The following is a description of a gene set: SARS-CoV-1 encodes eight subgenomic RNAs, mRNA2 to mRNA9. mRNA1 corresponds to the genomic RNA. The 5' and 3' ends of subgenomic RNAs are identical, in accordance with the template switch model of coronavirus RNA transcription. Genomic positive strand RNA is first transcribed into negative sense (minus strand) subgenomic mRNAs by template switching. Negative sense mRNAs subsequently serve as templates for the synthesis of positive strand subgenomic mRNAs. As shown in murine hepatitis virus (MHV), which is closely related to SARS-CoV-1, negative-sense viral RNAs are present in much smaller amounts than positive-sense RNAs. Of the eight subgenomic mRNAs of SARS-CoV-1, mRNA2 encodes the S protein, mRNA3 is bicistronic and encodes proteins 3a and 3b, mRNA4 encodes the E protein, mRNA5 encodes the M protein, mRNA6 encodes protein 6, and bicistronic mRNA7, mRNA8 and mRNA9 encode proteins 7a and 7b (mRNA7), 8a and 8b (mRNA8), and 9a and N (mRNA9), respectively. The template switch model of coronavirus involves discontinuous transcription of subgenomic RNA, with the leader body joining occurring during the synthesis of minus strand RNAs. Each subgenomic RNA contains a leader transcription regulatory sequence (leader TRS) that is identical to the leader of the genome, appended via polymerase “jumping” during negative strand synthesis to the body transcription regulatory sequence (body TRS), a short, AU-rich motif of about 10 nucleotides found upstream of each ORF that is destined to become 5' proximal in one of the subgenomic mRNAs. The 3' and 5'UTRs may interact through RNA–RNA and/or RNA–protein plus protein–protein interactions to promote circularization of the coronavirus genome, placing the elongating minus strand in a favorable topology for leader-body joining. The host protein PABP was found to bind to the coronavirus 3' poly(A) tail and to interact with the host protein eIF-4G, a component of the three-subunit complex that binds to mRNA cap structures, which may promote the circularization of the coronavirus genome. Two viral proteins that bind to the coronavirus 5'UTR, the N protein and nsp1, may play a role in template switching. The poly(A) tail is necessary for the initiation of minus-strand RNA synthesis at the 3' end of genomic RNA. Elongation of nascent minus strand RNA continues until the first functional body TRS motif is encountered. A fixed proportion of replication-transcription complexes (RTCs) will either disregard the TRS motif and continue to elongate the nascent strand or stop synthesis of the nascent minus strand and relocate to the leader TRS, extending the minus strand by copying the 5' end of the genome. The completed minus-strand RNAs then serve as templates for positive strand mRNA synthesis. Reactome Pathway: Transcription of SARS-CoV-1 sgRNAs part of: SARS-CoV-1 Genome Replication and Transcription species: Homo sapiens, and this is the list of marker genes: SARS coronavirus, complete genome, 1a, rep, N